Given this list of marker genes Dab2, Cdc20, Pink1 (NCBI Gene Id 68943), Dcun1d5, Gnas, Faf1, Sumo1, Crebrf, Tent5b, Rnft2 (NCBI Gene Id 269695), Nfe2, Tnks1bp1, Clip3, Akt2, Eif5a, Hdac2, Cdk2ap1, Rock2, Casp8, Ptafr, Atg10, Pla2g10, Oaz2, Card10, Slc1a1, Dtnbp1, Ccr7 (C-C motif chemokine receptor 7), Marchf2, Tspan9, Ndn, Rack1, Il6, Ifnb1, Arrdc3, Nnmt, Ccl19-ps3, Ngrn, Ier3, Herpud1, Higd1a, Rps4x, Nfkbia, Tesk1, Cln6, Dact1, Epo, Ptk2b, Cx3cl1, Sez6, Lrrn3, Oprd1, Birc5, Fas, Birc2, Csf3, Gdnf, Il18, Aplnr, Cdk5r1, Spon1, Ythdf2, Prkaa2, Cul3, Efna5, Soat1, Disc1, Ccl21a, Tnk2, Ptk2, Nsun5, Il21, Tbc1d7, Tcf7l2, Pxylp1, Traf2, Cd44, Msn, Trpc6, Ercc6, Rasa1, Sgta, Adipor2, Nedd4l, Sema4d, Prlr, Gfra1, Irgm2, Fgf15, Capn3, Fastkd3, Map2k4, Rictor, Pim1, Mrps27, Acvr1, Fgfr4, Osbpl7, Ppp1r15a, Bbs7, Bmpr2 (NCBI Gene Id 98751), Fanci, Ctsh, Csnk1e, Syap1, Eif2ak3, Fxr2, Csf1r (NCBI Gene Id 12978), Mapk9, Gper1, Cul4b, Camkk2, Mlst8, Eif3e, Mapre3, Nmi (NCBI Gene Id 64685), Peli1, Perp, Itgb1, Wnt3a, Abca2, Sirt2, Bmp4, Ep300, Rpusd4, Adcy8, Trim67, Elavl1, Rapgef2, Ccl19-ps1, Dnaja3, Smurf1, Snx9, Pde5a, Skp1, Antxr1, Anxa2, Lif, Gab1, Cenpe, Uhmk1, Lilra5, Il33, Flt3, Pld1, Rassf2 (NCBI Gene Id 99374), Larp4, Snca, Dock7 (dedicator of cytokinesis 7), Strada, Fbxo22, Cntf, Vps28, Topors, Rbm3, Rwdd3, Trim6, Grn, Usp5, Jmjd4, Fam161a, Ednrb, Ppp2r3a, Agap2, Ifngr1, Cdkn1b, Klf2, Rps6kb2, Zyg11b, Aurka, Mad2l2, Arhgef5, Ube2v2, Fgf8, Mmd2, Abcb10, Areg, Arl2bp, Wbp1l, Erbb4, Parp14, Map2k3, P2rx7, Aph1c, Abi1, Nck1, Crlf1, Traf4, Kitl, Ubxn2a, Tnfaip3, Cntn2, Vps11, Il6st, Gga1, Hspa5, Pik3r6, Met, Pik3r3 (NCBI Gene Id 99994), Ube2s, Isl1, Hpx (NCBI Gene Id 15458), Cd6, Fadd, Spry2, Egf, Eif5a2, Tnfrsf14, Kif14, Bmp2, Fnip1, Crebl2, Cemip, Rac1, Egfr, Nscme3l, Paqr3, Ang2, Mdm2, Tpx2 (TPX2, microtubule-associated), Cdk2ap1rt, Cdc20b, Cpeb3, Pias4 (protein inhibitor of activated STAT 4), Tirap, Dcun1d1, Prr16 (proline rich 16), Grk3, Rps2, Ldlr, Slc2a13, Reln, Ang5, Phip, Dab2ip, C3, Limk2, Drd1, Agrn, Pten, Rgn, Tbx1, Ago2, Gpr39, Sphk1, Pcsk9, Ddrgk1 (DDRGK domain containing 1), Mavs, Nkd1, Ntrk2, Cd3e, Mmp9, Ppp2ca, Mylip, Sirt1, Clcf1, Oga, Ube3a, Ins1, Asph, Aktip, Cd74, Ptger3, Tcim, Fbxo11, Ssb, Oaz3, Cry1, Smyd5, Rgma, Cdkn2a, Aimp2, Spn, Gsap, Mre11a, Niban1, Il24, Fgfr3, Bcl10, Yes1, Kdr, Edn1, Cck, Itgb1bp1, Aif1, Rnf139, Nkd2, Chfr, Ern1, Cspg4, Mprip, Flt1, Fgf10, Ddr2, Itln1, Otud6b, Nrxn1, Psrc1, Nsmce3, Rap2c (RAP2C, member of RAS oncogene family), Trf, Map3k12, Fbxo33, Iqgap1, Sh3rf2, Trmt10c, Sh2d1b1 (NCBI Gene Id 26904), Ccl19, Lin28a, Tollip, Tnik, Fancm, Birc3 (baculoviral IAP repeat-containing 3), Nos1, Rbm4, Timm23, Dnajb2, Prkag2, Trpc5, Il15, Dynapl1, Cd40, Cd300ld3, Asb5 (ankyrin repeat and SOCs box-containing 5), Ager, Egr1, Larp1, S100a10, Sh3d19, Ptpn1, Hamp2, Rps3, Pacsin3, Cop1, Fzr1, Ptpn11, Plk3, Pcif1 (phosphorylated CTD interacting factor 1), Abi3, Agtr1a, Thbs1, Eif4a3, Slco3a1, Det1, Cldn19, Uhrf1, Plxnb2, Efna3, Slc2a10, Fgf1, Tfrc, Sox4, Abi2, Klf4, Ripk1, Rab7, Atf2, Trem2, Nod2, Nr1h2, Krt17, Il13, Fgfr1, Pttg1ip, Fnta (farnesyltransferase, CAAX box, alpha), Ccl5, Als2, Bank1, Prss22, Cops8, Jak2, Plaur, Ddx39b, Lpcat1, Prmt1 (protein arginine N-methyltransferase 1), Akap6, Bdnf, Rchy1, Ptprz1, Map3k11, Nsf, Mettl5, Angptl8, Pdgfb, Hsp90aa1, Magi3, Map2k7, Eno1, Cdk5rap1, Sh3rf3, Mmp14, Rapgef3, Aph1b, Cblb, Ltf, Eif4g1, Gja1, Tes3-ps, Pabir1, Eif2b5, Braf, Tnfrsf18, Fxr1, Xrcc5, Map3k7, Sh2d1b2, Cul4a, Wnk4, Dok7, Trim30a, Lrp1, Igf1, Gabarap, Paip1, Snx1, Limch1, Ptprc, Ranbp9, Ndufa13, Dda1, Spatc1l, Nsun4, Ighm, Ube2k, Cab39, Snf8, Sema7a, Rxra, Hcls1, Mbl2, Spdye4a, Chek2 (checkpoint kinase 2), Ufl1, Dvl3, Vgll4, Phf23, Zfand2a, Fbxw11, Sesn2, Hnrnpd, Ctnnd1, Sorl1, Clec7a, Mtpn, Robo1 (NCBI Gene Id 436378), Mapkap1, Bag4, Atxn3, Ptger4, F12, Cass4, Iqgap3, Pkm, Bak1, Cfl1, Pik3cg, Etaa1, Sumo3, Tnp2, Kit, Axin2, Hnrnpu, Cep295, Dynap, Egln2, Trabd2b, Ptpn5, Prelid1, Lrp4, Dusp19, Brat1, Tmem259, Hax1, Ntf3, Rab3gap1, Ddx3x (DEAD box helicase 3, X-linked), Hmga2, Ripk2, Zp3r, Pik3r5, Nkx3-1, Inava, Itgb3, Parp9, Meltf, Irak1, Gba1, Csf1, Cxcr4, Hnf1a, Jtb, Sgsm3, Il6ra, Nat10, Slc8a2, Rassf5, Src, Casp3, Plgrkt, Xrcc6, Erbb2, Stub1, Prkch, Fam107a, Plk2, Ngf, Ptbp1, Hipk2, Mettl8, Svip, Cdc25b, Rb1cc1, Stx5a, Rab1b, Srcin1, Tcl1, Agtpbp1, Dvl1, Sh3rf1, Flt3l, Wnk3, Crkl, Pawr, Sox17, Cd46, Eng, Ralbp1, Nox4, Ticam1, Derl1, Skp2, Pdgfrb, Adra2a, Tek, Tmx1, Tgfb1, Nub1 (NCBI Gene Id 80634), Pfn2, Cldn4, Pak2, Gsk3a, Mastl, Tlr6, Prr5, Tmtc3, Brms1, Taok3, Fbxo4, Hamp, F2, Ubqln2, Tarbp2, Barhl2, Rptor, Il4, Dip2b, Wfs1, Abl1 (c-abl oncogene 1, non-receptor tyrosine kinase), Mettl3, Dazl, Slc6a9, Slc25a37, Eif4g2, E330034G19Rik, Fyn, Rnf180, Rpl26, Sez6l2, Icam1, Pla2g6, Cd80, Itga5, Fmr1, Efna1, Ppp2r3c, Cd4, Osbp, Sae1, Fcer1a, Map3k10, Rbx1-ps (ring-box 1, pseudogene), Hspbp1, Flot1, Sfrp2, Thbs4 (NCBI Gene Id 21828), Golga2, Hras, Abcg1, Ubqln1, Eno1b, Tnip1, Lrrk2, Agbl4, Ceacam1, Bcap31, Clspn, Trim32, Unc119, Tnp1, Adam8, Pdgfc, Rnf111, Pdgfra, Ccbe1, Fzd1, Akt1, Tnfsf11, Pomt1, Tead1, Pias3, Mapk8, Dhx9, Rela, Dip2a, Ntrk1, Dcaf1, Mrnip, Bcl3, Socs4, Ramp1, Serp1, Ripk3, Nhlrc1, Stradb, Ins2, Eif4a3l1, Dtl, Cib1, Plpp3, Vangl2, Smyd3, Kat5, Sez6l, Ccn2, Vsir, Rspo1, Axin1, Traf7, Cldn3, Pik3r1, Cx3cr1, Kcne2, Txn1, Habp4, Ndfip2, Ogt, Rcn3, Trub2, Nedd4, Htr2a, Nptn, Ube2srt, Nedd9, Fgf2, Tlr9, Slc51b, Mpv17l2, Rassf1, Traf6, Itga2, Insr, Cav2, Pik3c3, Cdon, S1pr2, Mydgf, Mustn1, Cyfip2, Prnp (NCBI Gene Id 98923), Pef1, Stil, Spsb4 (splA/ryanodine receptor domain and SOCS box containing 4), Rap2a, Adra2b, Prickle1, Nr1h3, Lck, Dlg1, Ube2n, Pdgfa, Tab1, Poldip3, Angpt4, Kndc1, Sumo2, Bmal1, Tom1l1, Fnip2, Dhx29, Ucn, Hes1, Fam20a, Bcl2, Socs5, Eif4g3, Slc11a1, Wdfy2, Tspyl5, Ret, Ifng, Fndc1, Chrna3, Il17f, Tab2, Pcbp1, Rmnd1, L3mbtl3, Ezh2, Epha4, Ctnnb1, Notch2, Fgf4, Fbxl5, Mapk1, Dcun1d2, Bag6 (NCBI Gene Id 80605, BCL2-associated athanogene 6), Stat3, Arhgef2 (NCBI Gene Id 99482), Zer1, Aph1a, Hes5, Rilp, Psen2, Pym1, Ncstn, Il12a, Map2k6, Klhl40, Fzd8, Adam9 (ADAM metallopeptidase domain 9), Ern2, Reg1, Rnf41, Pik3ca, P2ry1, Rbms3, Htr2b, Akap11, Bmi1, Bad, Irgm1, Ube2d1, Dab1, Rap2b, Il31ra, Inhba, Stk4, Agt, Pabpc1, Map3k13, Vldlr, Pemt, Fgf18, Trib3, Zcchc4, Pdcd6, Fgd4, Mul1, Adra2c, Card14 (caspase recruitment domain family, member 14), Hmgb1, Huwe1, Vegfb, Rad23a, Plcb1, Ubb, Tfr2, Adnp, Gsk3b, Trim65, Rps6kb1, Fgf7, Psenen, Atg4b, Plk1, Pml, C1qbp, Ccdc22, Khdrbs1, Apoe, Dcun1d4, Prkcd, Rap1a, Chga, Fbxw7, Map4k2, Lrrtm3, Prkn, Ctsc, Ppia, Picalm, Pih1d1, Cartpt, Wnt5a, Tiparp, Ccn1, Ccl19-ps6, Eif2a, Ahrr, C4bp, Mmd, Neurl1a, Cbfa2t3, Vip, Apc, Marchf7, Agtr1b, Uba2, Npm1, Mycbp2, Cdk5r2, Rnf185, Mapk7, Hsf1, Spdya, Fiz1, Wdr24, Rnf40, Cdk4, Pde4d, Mettl14, Ddb1, Il17d, Mta1, Rab1a, Trib2, Rarres2, Rpl5, Bmp6, Stox1, Abcf1, Laptm5, Nop53, Lats1 (NCBI Gene Id 16798), Csnk1a1, Arnt, Polr2g, Hspa1a (NCBI Gene Id 193740), Chp1, Kdm1a, Usp13, Eef2, Ccnd3, Park7, Commd1, Adrb2, Maged1, Pomt2, Ccl19-ps5, Ldb1, Vcp, Mbp, Usp8, Lyn, Card9, Gprc5b, Drd4, Dnajc3, Adcyap1, Tbc1d10a, Eif2ak4, Emp2, Pecam1, Csf2, Asb11, Ang4, Psen1, Araf, Flt4, Bcar3, Vegfa, Piwil2, Rcc1l, Ecscr, Lep, Mir466l, Birc7, Taok1, Tnfrsf1a, Chi3l1, Tnf, Tm9sf5, Zeb2, Map3k1, Cd81, Akap9, Odam, Rps27l, Trim23, Cldn13, Timm17a, Cacul1, Mt3, Ube2v1, Ist1, Ccny, Ang6, Crh, Ang, Atp5if1, Ythdf3, Enpp2, Tnfsf18, Hdac3, Paxip1, Vegfc, Ccl19-ps4, Nrg1, Mtor, Hspa1b, Cntn1, Atg14, Il12b, Aurkaip1, Rasd2, Csde1, Prom2, Tnfrsf1b, Zc3h12a, Syk, Fzd4, Edn3, Ptpn22, Zfp91, Tlr4, Clu, Chrna7, Rhoa, Sirt6, Cryaa, Prox1, Dhx36, Csnk1d, Map3k4, Map3k5, Usp16, Gpld1, Stk11, Hspa8, Gpc3, Psmd10, Arrb2, Hbegf, Il3, Hspa2, Erp29, Boll, Tank, Rad50, Gsn, C1qtnf9, Il2, Secisbp2, Fgd2, Prkca, Map2k5, Ccnd2, Zcchc13, Igtp, Tnfsf12, Rdx, Ythdf1, Gclc, Prkdc, Adcy10, Tmem67, Pdcd10, Sprtn, Il5, Wnt1, Thpo, Myh9, Reg3b, Ect2, Sqstm1, Cripto, Prkd1, Nbn, Adtrp, Ntrk3, Nrdc, Kras, Arrb1, Arid5a, Sh3bgrl, Tlr1, Cd24a, Astl, Il11, Atg7, D1Pas1, Guf1, Clec3b, Wdr59 (WD repeat domain 59), Btrc, Avp, Sec22b, Samd4, Ttbk1, Tnfrsf11a (NCBI Gene Id 21934), Pkp1, Sox9, Ereg, Ccnd1, Sp1, Pias1, Rhbdd3, Nlrc4, Grem1, Ccdc88a, Gga3, Amer1, Dgkq, Ndfip1, Slc35a4, Pxn, Asb9, Fastkd2, Cln3 (NCBI Gene Id 12752), Lrp8, Foxo1 (forkhead box O1), Ednra, Pak1, Cyp1b1, Csnk2a1, Vps35, Larp4b, Lrrk1, Il1b, Hpn, Ncor2, Senp2, Upf3b, Ralb, Map2k2, Mob2, Nek10, Rpusd3, Cdk5, Ube2l3, Septin4, Eif6, Prkaa1, Hdac6, Mapk8ip3, Cav1, Xiap, Coa3, Cnbp, Camp, Xbp1, Rhbdd1, Mapk15, Syncrip, Fuz, Peli2, Mst1r, Pin1, Tsacc, Tgfb1i1, Cpeb1, Fbxw8, Upf3a, App, Adipoq, Gpnmb, Il34, Nelfe, Nelfa, Sash1, Cnot9 (NCBI Gene Id 98400), Cdc14b (CDC14 cell division cycle 14B), Fzd5, Rbx1, Oaz1, Map2k1, Arrdc4, Ilk, Camk1 (NCBI Gene Id 52163), Igf2bp1, Eif3d, Tpd52l1, Eif4a3l2, Ezr, Rab3gap2, Gata1, Rnft1, Angpt1 (angiopoietin 1), Rigi, Pibf1, Dvl2, Ctf1, Trib1, Hdac4, Daxx, Rasgrp1, Wnt7a, Ehd4, Rgcc, Fbh1, Tgfb2, Cdk5rap3, Prr5l, Vtn, Raf1, Cdkn1a, Bag2, Tenm1, Tgfa, Mif, Dcun1d3, Faxdc2, Gas6, Osm, Itch, Ubr3, Uqcc2, Adam17, Ybx1, Lepr, Gnl3, Nupr1, Ip6k2, Ajuba, Musk, Mapk3, Fbn1, Nck2, Acvr2a, Pin1rt1, Akap5, Il23a, Cirbp, Aspscr1, Snx33, here is a description of the gene set: species: Mus musculus Mouse Gene Set: GOBP_POSITIVE_REGULATION_OF_PROTEIN_METABOLIC_PROCESS Any process that activates or increases the frequency, rate or extent of the chemical reactions and pathways involving a protein.